The following is a description of a gene set: Any process that modulates the frequency, rate or extent of action potential creation, propagation or termination in a neuron. This typically occurs via modulation of the activity or expression of voltage-gated ion channels. studied in species Mus musculus Mouse Gene Set: GOBP_REGULATION_OF_NEURONAL_ACTION_POTENTIAL, and this is the list of marker genes: Ffar3, Gpr35, Gba1 (glucosylceramidase beta 1), Fmr1, Rapgef4, Mtnr1b, Kcnc4, Trpa1, Chrnb2, Fgf12, Ifng, Chrna5, Pawr, Cntnap2